The following is a description of a gene set: studied in species Mus musculus Mouse Gene Set: GOBP_PEPTIDE_MODIFICATION The covalent alteration of one or more amino acid residues within a peptide, resulting in a change in the properties of that peptide., and this is the list of marker genes: Lancl2, Pam, Lancl1, Ggt1, Lancl3